Given this list of marker genes LCN1, SLC27A4, SLC27A1, LCN9, SLC27A6, LCN15, LCN12, APOD, here is a description of the gene set: part of: Transport of vitamins, nucleosides, and related molecules studied in species Homo sapiens Reactome Pathway: Transport of fatty acids Long chain fatty acids (LCFAs) are involved in many cellular functions. They can be used as an important source of energy by skeletal muscle and heart tissues. Also, they are used in the production of hormones which can regulate inflammation, blood pressure, the clotting process, blood lipid levels and the immune response. Fatty acid transporter proteins (FATPs) are a family of proteins which mediate fatty acid uptake into cells when overexpressed. FATPs also possess enzymatic activity, the details of which are captured elsewhere. There are 6 human genes of the SLC27A family which encode for FATP1-6 (Stahl A, 2004; Gimeno RE, 2007). To date, only FATP1, 4 and 6 have demonstrable transporter function. Fatty acids with carbon chain lengths of more than 10 are the most likely substrates for these transporters.